Given this list of marker genes CUX1, MADCAM1, BEND3, STX3, PLCG1, ENG (NCBI Gene Id 2022), ABCA2, KCNJ13, SLC39A4, ZMAT3, PLA2G5, GRIK5, CFAP70, OTOS, RASGEF1A, NCR1, DRC12, RBM47, SERPIND1, PRDM14, MYO18B, UMOD, IRX6, IER3, KCNH2, CPPED1, ROBO4, RPL27, AFAP1L1 (NCBI Gene Id 134265), ADGRL1, LIN28A, VAT1, KRBA1, IRF4, RPUSD2, CFI, CASR, MYO1F, SH3GL3, CAPN5, COX6B2, MELTF, BPIFB3, SELPLG, TRPS1, ZYX (zyxin), SLC7A13, MOV10, LPAR4, ST3GAL4, EXT2, SIK1, GLIS2, FYB1, PML, RECK (NCBI Gene Id 8434), CCND2, MEG3, FGF21, PRKCE, MEX3A, RAD54L2, CX3CR1, S100A11, UNC5D, CCR2, ACE, MPP3, RBM4B, CARMIL1, LPIN1, GLYCTK, TNFRSF25, SYNE2, CD80, PHC1, FBXL19, ADCY6, ZC3H12C, LEF1, PRKCH, ANKS1A, TSPAN6, TMEM104, INF2, FHL1, NEK6, SYNJ1, NRIP2, CPEB1, GCNT2, GFRA1, LGALS12 (galectin 12), USP45, OTULINL, USP22, TDRD5, EHBP1L1, EPS8, VCL, COL10A1, ACY3, GATC, FGF3, KRT72, PPP2R3A, RIPOR3, GNG7, GLIPR2, DNMT3A, ARMCX4, ARAP3, MAP4K2, FUT2, ZBTB10, CD300A, XYLT2, CDKN2B, STAP2, BAHD1, AHNAK (AHNAK nucleoprotein), FFAR3, BHMT, DOCK5, XRCC3, MEFV, SLC25A23, PIM2, SNX18, TMEFF1, DSG2, GUCY2F, TM4SF19, HOXC6, VANGL2, PCBP3, RUNX3, ANGPT2, AHDC1, PIK3R6, NNAT, DAAM1, ZFR2, LDLRAD3, CHST5 (carbohydrate sulfotransferase 5), CPEB3, LRTM2, IKBIP, CUL7, CCDC40, JARID2, CACNB2, CNKSR3, KLHL22, here is a description of the gene set: Dendritic cells (DCs) process and present self and foreign antigens to induce tolerance or immunity. In vitro models suggest that induction of immunity is controlled by regulating the presentation of antigen, but little is known about how DCs control antigen presentation in vivo. To examine antigen processing and presentation in vivo we specifically targeted antigens to the two major subsets of DCs using chimeric monoclonal antibodies. Unlike CD8+ DCs that express the cell surface protein CD205, CD8- DCs, which are positive for the 33D1 antigen, are specialized for presentation on MHC class II. This difference in antigen processing is intrinsic to the DC subsets and associated with increased expression of proteins associated with MHC processing. studied in species Homo sapiens Genes down-regulated in splenic DEC205+ dendritic cells versus CD8 T cells. Human Gene Set: GSE6259_DEC205_POS_DC_VS_CD8_TCELL_DN from publication Dudziak D, Kamphorst AO, Heidkamp GF, Buchholz VR, Trumpfheller C, Yamazaki S, Cheong C, Liu K, Lee HW, Park CG, Steinman RM, Nussenzweig MC (PMID 17204652)